Given this list of marker genes Atp2a2, Neurod1, Ctbp2, Phc3, Tril, Tmem220, Htr4 (NCBI Gene Id 15562), Ccnl1, Rgs4, Tjp1, Stip1, Mphosph6, Lyset, Piezo1, Shprh, Rhot1, Stag1, Sim1, Zfand6, Ift80 (NCBI Gene Id 68259), Irf2, Lnx2, Yipf4, Cdk4, Zfp24, Pcdh15, Ifnk, Pof1b, Zeb2, Sh3bgrl, Ptprg, Entpd1, Dennd6b, Sp3, Arg2, Ngf, Rpain, Secisbp2l (SECIS binding protein 2-like), Lamp3, Bsn, Mycbp2, Ing1, Myo16, Dusp1, Arl13b, Dctn6, Zfp239, Pdgfra, Ubn2, Fgl2, Bclaf1, Rwdd4a, Mrpl17, Nckap1, Col13a1, Zfp1006 (zinc finger protein 1006), Cadm2, Rac3, Cyp26b1, Bmyc, Ppil4 (peptidylprolyl isomerase (cyclophilin)-like 4), Cntn1, Syt4, Jrkl, Pde3b, Fst, Lrrc7, Tipin, Cdk19, Lcorl, Mctp1, Rnf214 (NCBI Gene Id 235315), Rad51d, Tmem229a, Prdm1 (NCBI Gene Id 12142), Hdac9 (NCBI Gene Id 79221), here is a description of the gene set: Mouse Gene Set: MIR_344H_3P Genes predicted to be targets of miRBase v22 microRNA mmu_miR_344h_3p in miRDB v6.0 with MirTarget v4 prediction scores > 80 (high confidence targets). species: Mus musculus from publication Chen Y, Wang X (PMID 31504780)